The following is a description of a gene set: Right ventricular dysfunction (global or regional) with functional and morphological right ventricular abnormalities, with or without left ventricular disease. studied in species Homo sapiens Human Gene Set: HP_RIGHT_VENTRICULAR_CARDIOMYOPATHY Right ventricular cardiomyopathy, and this is the list of marker genes: DSC2, DSP, DSG2, JUP, TGFB3, PKP2, TMEM43